The following is a description of a gene set: species: Mus musculus Mouse Gene Set: GOBP_CELL_SURFACE_RECEPTOR_PROTEIN_SERINE_THREONINE_KINASE_SIGNALING_PATHWAY The series of molecular signals initiated by an extracellular ligand binding to a receptor on the surface of the target cell where the receptor possesses serine/threonine kinase activity, and ending with the regulation of a downstream cellular process, e.g. transcription., and this is the list of marker genes: Bmp6, Nanog (NCBI Gene Id 71950), Bmpr1b, Spart, Itgb1, Numa1, Slc2a10, Pmepa1, Sin3a, Arid4b, Lrp2, Mir23a, Mir744, Hipk2, Ctdspl2 (NCBI Gene Id 51895), Fermt1, Ndp, Mir210, Zfp451, Smad5, Ski, Twsg1, Bmp5, Cidea, Mir130a, Glce, Onecut2, Synj2bp, Rasl11b, Tgfbr3, Cilp, Ccn1, Cdh5, Wfikkn1, Itgb5, Cav1, Gdf3, Etv2, Cldn5, Inhba, Wwtr1, Mir145b, Ilk, Htra3, Htra1 (HtrA serine peptidase 1), Skor1 (SKI family transcriptional corepressor 1), Chst11, Crb2, Folr1, Rgma, Acvrl1, Pelo, Egr1, Sostdc1, Fgf10, Flcn, Bmp2, Ldlrad4, Bmp4, Brms1l, Neo1, Sfrp1, Ppm1l, Map3k7, Sulf1, Lpxn, Atf2, Gdf6, Gdf11, Spry1, Crim1, Hspa5, Arrb2, Arid4a (AT-rich interaction domain 4A), Zeb1, Cited1, Cdh3, Dcp1a, Megf8, Tgfbr1, Hfe, Gcnt2, Ror2, Mtmr4, Ing2, Dact1 (dishevelled-binding antagonist of beta-catenin 1), Spry2, Gdf2, Crebbp, Becn1, Myd88, Furin, Mirlet7b, Col3a1, Gpc3, Gata6, Itgb8, Prdm16, Tgfbr2, Mstn, Trp53, Notch1, Slc39a5, Snx25 (sorting nexin 25), Ext1, Ptprk, Stat3, Id1, Pakap, Mir143, Sh2b1, Bmncr, Gdnf, Magi2, Dlx1, Mir125a, Tmem100, Ark2c, Mir181d, Pparg, Smpd3, Ovol2, Xbp1, Tgfbr3l (NCBI Gene Id 100044509), Eng, Got1, Zeb2, Chrd, Ltbp3, Gpr155, Strap, Acvr1b, Col1a2, Fbn1, Spi1, Ecsit, Mirlet7d, Lemd2, Fbxl15 (NCBI Gene Id 68431), Tgfb1i1, Bcl9l, Smad4, Tgfb3, Mir382, Tbx20, Dact2, Acvr1, Mirlet7f-2, Nog, Gata4, Cd109, Suds3 (suppressor of defective silencing 3 homolog (S. cerevisiae)), Ryr1, Mir329, Men1, Tgfb1, Gdf7, Sptbn1, Mir290a, Nkx2-1, Ube2o, Cited2, Tgif2, Rnf111, Spred3, Pxn, Skil, Trim33 (NCBI Gene Id 99609), Ly6g6e, Wfikkn2, Mir185, Smurf2, Fkbp1a, Hjv (NCBI Gene Id 99714), Pals1 (protein associated with LIN7 1, MAGUK family member), Inhbb, Wnt3a, Chrdl2, Brms1, Thbs1, Hsp90ab1, Fstl4, Aspn, Tnrc6c, Vwc2l, Ing1, D130043K22Rik, Tet1, Zc3h3 (zinc finger CCCH type containing 3), Jak2, Cdkn1c, Pdcd4, Map3k1, Ccl2, Wnt5a, Smad3, Arap1, Rbpms, Smad6, Nodal, Il17rd, Kcp, Mir7-2, Acvr2a, Acvr1c, Fbn2, Mir25, Zcchc12, Zbtb7a, Dnm2, Nepn, Mirlet7f-1, Igsf1, Fgf9, Foxd1, Ogt, Rbpj, Fos, Ero1a, Veph1, Hpgd, Zfp423, Smad2, Ppara, Usp15, Bmper, Stk11, Fstl1, Itga8, Sdcbp, Mir145a, Elapor2, Vwc2 (NCBI Gene Id 319922), Usp9x, Cav2, Tnfaip6, Gdf15, Bmp8a, Adam17, Bambi, Hivep1, Snx6, Mapk14, Smad9, Mir147, Eid2, Ucma, Appl1, Pbld2, Akap3, Wnt1, Vsir, Tmem53, Emilin1, Cripto, Dlx3, Lgals9, Dsg4, Selenon, Mapk3, Snx1, Fut8, Cav3, Appl2, Rgmb, Nlk, Smurf1, Nfia, Onecut1, Tab1, Ltbp1, Dand5, Peg10, Lrg1, Smad7, Zfp128, Chrdl1, Ptk2, Ccn3, Bmp8b, Lrp1, Zic2, Amhr2, Grem2, Sorl1, Dkk1, Adissp, Vasn, Dmrt1, Hdac2, Kdr, Prmt1, Npnt, Mir181c, Hoxa13, Trps1, Sinhcaf (SIN3-HDAC complex associated factor), Sox11, Bmpr1a, Tgfb2, Fstl5, Cer1, Tgif1, Adamtsl2, Mirlet7a-1, Akap7, Cfc1, Hes5, Notch2, Zyx, Ep300, Ngly1, Lox, Lef1, Pdpk1, Grem1, Sap130, Glg1, Foxh1, Lefty1 (NCBI Gene Id 98355), Hdac1, Bmp10, Scx, Src, Fst, Acvr2b, Csnk2b, Skor2, Zmiz1, Hes1, Bmp7 (NCBI Gene Id 12162), Ddx5, Msx2, Atoh8, Rbbp7, Msx1, Lrrc32, Fkbp8, Runx2, Nup93, Dusp22, Sap30, Mir675, Sfrp4, Ppm1a, Itga3, Sirt1, Nrep, Tmprss6, Amh, Smad1, Fshb, Mir7-1, Ints9, Rbpms2, Snw1, Fam89b, Pml, Sost, Scube3, Mir122, Zfyve9, Gdf5, Tcf7l2, Sap30l, Mapk8, Myocd, Fam83g (NCBI Gene Id 69640), Pbld1, Erfe, Spred2, Lats2, Zfp703, Akap4, Abl1, Fstl3, Adam9, Tsc22d1, Tfap2b, Tob1, Bmpr2 (NCBI Gene Id 98751), Mir16-1, Pin1rt1 (peptidyl-prolyl cis/trans isomerase, NIMA-interacting 1, retrogene 1), Spred1, Dab2, Rbbp4, Axin1, Parp1, Nrros, Cdkn2b, Stub1, Ltbp4, Map1lc3a, Jun, Pin1, Creb1, Gipc1, Nbl1, Il17f, Itgb6, Tmem119, Comp (cartilage oligomeric matrix protein), Dlx5, Fzd1, Lemd3, Sfrp2, Lats1, Fermt2